Given this list of marker genes ZFP2, PTPRQ, TMEM116, TDRD6, ITGA8, RASGRP2, CYP7B1, DHDH, PRODH, RASSF4, MIR3936HG, PAIP2B, MBP, IQCN, SP2-AS1, DENND3, LINC02405, GRK4, FZD4-DT, ZBED3, NUDT16, PDE8B, GSTA7P, GHR, GCH1, HCG9, OCLNP1, SPINK5 (serine peptidase inhibitor Kazal type 5), FRAT1, KCNK5, SOD2-OT1, BTNL9, SLC6A16, ACACB, ADARB2, NUDT8, ABCD2, EPHA10, LAIR1, ADGRF5, MUCL1, FGD4, RAB26, USP43, SLC26A9, JAKMIP2, TACC2, RALGPS1, NR3C2, LINC01554, CFAP144P1, BEST2, FBXO27, STOX1, TMEM8B, FGD3, PARD6B, MRC1, RNF148, ID2-AS1, A1BG, RPGRIP1, IL6ST-DT, DHRS9, BCO2, GASK1A, LINC00482, C5orf46, SLIT2, TRMT9B, here is a description of the gene set: Transcriptome of human HepaRG hepatocellular carcinoma liver progenitors in responses to a WNT3A-enriched microenvironment and dissection of pathways dependent on _-catenin and/or blocked by the SFRP-like Wnt inhibitor FZD8_CRD. from publication Mebarki S, Désert R, Sulpice L, Sicard M, Desille M, Canal F, Dubois-Pot Schneider H, Bergeat D, Turlin B, Bellaud P, Lavergne E, Le Guével R, Corlu A, Perret C, Coulouarn C, Clément B, Musso O (PMID 27191501) Human Gene Set: MEBARKI_HCC_PROGENITOR_WNT_DN_BLOCKED_BY_FZD8CRD Methods: Liver progenitor cells were incubated in a WNT-enriched microenvironment for 72hrs (200 ng/ml mouse recombinant purified Wnt3A from R&D Systems). Gene pathways dependent on downstream _-catenin were studied by _-catenin knockdown with specific siRNA. Gene pathways blocked by extracellular SFRP-like Wnt inhibitors were studied by co-incubating cells with recombinant purified FZD8_CRD (300 ng/ml, from R&D Systems). Independent culture experiments performed in triplicate include untreated cells or cells incubated with scrambled siRNA or with _-catenin-specific siRNA or with FZD8_CRD, alone or in combination with Wnt3A. species: Homo sapiens